Given this list of marker genes TMEM39A, TMEM98, ATP6V0A2, PAXX, ELL2, SUCNR1, RELN, CRYL1, GPR61, CHERP, C8G, PROX1, LUC7L2, MPHOSPH8, MFN1, PEX19, UTP4, NEK4, PTGDS, AR, ABCG5, CMKLR1, YBX3, GSTM5, TSR1, SECISBP2, C7orf25, GTPBP4, MACROH2A1, SORBS2, MYLK, MSL1, USF2, MASP1, TBCEL, P2RY1, LINC00261, GHR, VCPIP1 (NCBI Gene Id 80124), EIF4A3, CD109, here is a description of the gene set: Human Gene Set: CHANGOLKAR_H2AFY_TARGETS_DN species: Mus musculus Genes down-regulated in liver tissue upon knockout of H2AFY. from publication Changolkar LN, Costanzi C, Leu NA, Chen D, McLaughlin KJ, Pehrson JR (PMID 17242180) macroH2A histone variants have been implicated to function in gene silencing by several studies, including ones showing a preferential association of macroH2A on the inactive X chromosome. To examine macroH2A function in vivo, we knocked out macroH2A1. macroH2A1 knockout mice are viable and fertile. A broad screen of liver gene expression showed no evidence of defects in X inactivation but did identify genes that have increased expression levels in macroH2A1 knockouts. macroH2A1-containing nucleosomes are enriched on the coding and/or upstream regions of these genes, suggesting that their increased expression levels are a direct effect of the absence of macroH2A1. The concentrations of macroH2A1 nucleosomes on these genes are low in the livers of newborn mice, and the macroH2A1 knockout had little effect on the expression levels of these genes in newborn liver. Our results indicate that an increase in liver macroH2A1 during the transition from newborn to young-adult status contributes to a decrease in the expression levels of these genes. These genes cluster in the area of lipid metabolism, and we observed metabolic effects in macroH2A1 knockouts. Our results indicate that the function of macroH2A1 histones is not restricted to gene silencing but also involves fine tuning the expression of specific genes.